Given this list of marker genes Ptdss1, Ptdss2, here is a description of the gene set: Reactome Pathway: Synthesis of PS part of: Glycerophospholipid biosynthesis electronically inferred by orthology from the curated human pathway studied in species Mus musculus This event has been computationally inferred from an event that has been demonstrated in another species.<p>The inference is based on the homology mapping from PANTHER. Briefly, reactions for which all involved PhysicalEntities (in input, output and catalyst) have a mapped orthologue/paralogue (for complexes at least 75% of components must have a mapping) are inferred to the other species.